Given this list of marker genes HSPA1A, MIR219A1, DNAJB8, HSPA1B, IFNB1, DNAJA4, HSF1, HSPA2, SACS, DNAJB6, DNAJB2, DNAJB1, SORL1 (sortilin related receptor 1), here is a description of the gene set: Any process that decreases the rate, frequency, or extent of inclusion body assembly. Inclusion body assembly is the aggregation, arrangement and bonding together of a set of components to form an inclusion body. Human Gene Set: GOBP_NEGATIVE_REGULATION_OF_INCLUSION_BODY_ASSEMBLY studied in species Homo sapiens